Given this list of marker genes FGFRL1, FGFR2, FGFR3, FGFR4, FGFR1, here is a description of the gene set: Human Gene Set: GOMF_FIBROBLAST_GROWTH_FACTOR_RECEPTOR_ACTIVITY Combining with a fibroblast growth factor receptor ligand and transmitting the signal across the plasma membrane to initiate a change in cell activity. studied in species Homo sapiens